The following is a description of a gene set: Genes predicted to be targets of miRBase v22 microRNA hsa-miR-4668-3p in miRDB v6.0 with MirTarget v4 prediction scores > 80 (high confidence targets). Human Gene Set: MIR4668_3P studied in species Homo sapiens from publication Chen Y, Wang X (PMID 31504780), and this is the list of marker genes: TC2N, KLHL4, TM9SF2, ZNF143, ROBO2, HYCC2, MTPN, WDFY3, LOX, MFAP3, AFF2, VMA21, AP1AR, CACNB4, STRBP, YWHAE, EXOC6, ING3, H2AZ1, USP47, VPS36, STEAP2 (STEAP2 metalloreductase), FZD7, ATE1, FAM3C, AKAP7, SEM1, SLC6A2, TOX, ANK3, RPS6KB1, PAFAH1B1, SEC24A, MZT1, FAM20B, DYRK2, MEI4, CPED1, UBN2, EIF5A2, DEUP1, SPOCK3, TCF4, RAPH1, ABCE1, SLC7A11, STXBP5, PTPN4, STK38, FAM13C, RNF38, TMCC1, MBTD1, RPRD1A, SLC16A6, TMX4, RAB9A, TRPC1, NR1D2, REPS2 (NCBI Gene Id 9185), NFYB, PPFIA1, MDM1, MYLK3, FUT9, TAF12, FMR1, SLC7A8 (NCBI Gene Id 23428), PHIP, MIER3, RNF169, SPRTN, TBPL1, UBR2, SCN8A, HECTD2, ELAVL4, ADGRL3, SIKE1, PITPNB, OSTM1, HSF5, SLC9A9, RAB8B, NUP160, XRN1, VASH2, PNP, LARP4, PAK5, EOMES, ATP8A1, SHOC2, MRC1, C4orf19, CLINT1, OVOL2, CEP135 (centrosomal protein 135), TRIM5, DNMT1, PIK3CA, INO80D, NOTCH2, EXTL3, RUNX1T1, AAK1, DAZAP2, NFIA, C15orf32, PPM1E, SLC35A3, PRKCA, TCEAL8, ADRA2A, MSANTD2, SCAMP1, FAM171A1, PRTG, ZNF454, KLHL28, BEND3, ZFY, PPDPFL, HLTF, WDR47, ATAD2B, SLC16A7, SGK1, CEMIP2, PFKFB2, KHDRBS2, CPS1, KLHL31, SPACA9, TNFSF12, SLAIN2, FRAT1, GPATCH8, LIMK2, LYSMD3, GPM6B, PPP1CB, CLOCK, SNX25, RALGPS2, CELF1, ONECUT2, TNPO1, PLEKHM3, GOLGA1 (golgin A1), REV1, TUT7, ANKS1B, CNNM3, TAC3, BCL9 (BCL9 transcription coactivator, NCBI Gene Id 607), MINDY2, ATP1A1, HINT3, SPIN4, ZNF664, NR2C1, PTPRR, IRF6, HTR2C, SIN3A, C2CD2, PTPRD, ZFTA, MGAT4A, PKD2L2, QSOX2, ZZZ3, DCDC2, TM9SF3, TRIM25, RAD9B, POU3F1, ACBD3 (acyl-CoA binding domain containing 3), ODC1, ANOS1, FBXO3, PYGO1, NPHP3, UHRF2, DDB1, SLC39A5, ATAD2, AHCTF1, TVP23C, ERRFI1, SMIM13, ASGR1, CAND1, TRERF1, CUL5 (cullin 5), SP4, CHIC1, ADNP2, ZFHX3, ZC3H7A, FHIP1A, ZHX2, HACD4, ORC4, RC3H1, PCDH7, RNF180, PTGES3, CTDSPL2, GFI1, EPM2AIP1, NIPSNAP3B, SOX5, ARL13B, FNDC3B, ETS2, ISL1, KLF11, RAD51AP2, EDEM3, TXNRD1, JPH3, CDH2, SPATS2L, NXPE3, BRAF, PPFIBP1, ZSCAN2, FAM91A1, ZDHHC21, GGACT, UNC5D, UBE2Q2, BICDL1, BLOC1S4, CPEB2, HLF, ARFGEF1, FAM81A, RPS6KA2 (ribosomal protein S6 kinase A2), ESD, MKLN1, RBMS1, AHCYL1, MSI2, ZNF148 (NCBI Gene Id 7707), EIF5B, CDK19, FGD4, ZC3H12C, EFHB, BTBD7, ATF1, MBNL1, PGM3, CLVS2, PKHD1, FBXO8, ZCCHC2, ERCC6, CDK4 (cyclin dependent kinase 4), KITLG, S100PBP, SKIL, MEF2A, MPRIP, SRPK2, HSF1, CBX5, KMT2A, PDE4D, EPC2, ZBTB8B, TRIOBP, KAT6B, PTPN2, PELI2, CCDC186, HECA, OSBPL6, PPP1R15B, NAP1L5, DENR, USP38, SLC16A9, TRIM66, SLITRK1, USP13, TENM3, FAM83B, C2CD5 (C2 calcium dependent domain containing 5), RANBP2, NFIB, PAN3, LYRM7, COX18, OSTF1, RBM23, FBXO33, UBP1, CADM1, GSK3A